The following is a description of a gene set: Human Gene Set: GOBP_COMMISSURAL_NEURON_AXON_GUIDANCE species: Homo sapiens The process in which the migration of an axon growth cone of a commissural neuron is directed to its target in the brain in response to a combination of attractive and repulsive cues., and this is the list of marker genes: SMO, VEGFA, NFIB, ADAM17, NELL2, NRP1 (neuropilin 1), EPHB2, RYK, PTCH1, DAG1, NCAM1, GDNF, FZD3, ROBO3